The following is a description of a gene set: Any process that activates or increases the frequency, rate or extent of the chemical reactions and pathways resulting in the formation of proteoglycans, any glycoprotein in which the carbohydrate units are glycosaminoglycans. studied in species Homo sapiens Human Gene Set: GOBP_POSITIVE_REGULATION_OF_PROTEOGLYCAN_BIOSYNTHETIC_PROCESS, and this is the list of marker genes: CTNNB1, MUSTN1, SLC2A10, TCF7L2 (transcription factor 7 like 2), PXYLP1